Given this list of marker genes MYO1F, DYNLL2, MYO9A, MYO18B, MYL6, MYO7A, MYO6, MYL6B, MYO1C, here is a description of the gene set: A portmanteau term for myosins other than myosin II. species: Homo sapiens Human Gene Set: GOCC_UNCONVENTIONAL_MYOSIN_COMPLEX